Given this list of marker genes GNAS, UBTF, POLD4, VEZF1, HOXB6, FOXA2, FOXA3, KLHL5, SHQ1, ST7L, SRSF2, DNAJB5, PPOX, HS6ST3, ANGPT1, AMOT, TFAP2D, GRIK2, LHX6, TUBA1B, REPS2, KRIT1, ACTN1, NEURL1, MCTS1, DPYSL2, PLXNC1, PPP2R2A, GREM1, PHOX2B, LMO3, ABHD8, RAB34, SPEG, CDC27, ATXN7L2, NPNT, PDGFRA, ZNF335, FBXW7, GPBP1, OAZ2, TRA2A, HOXA10, SYNCRIP, NELFB, RPL8, NXPH3, RAB3C, CNNM1, ZNRF2, KPNB1 (NCBI Gene Id 3837), MFF, NFIA, SLC8A3, FAM131A (family with sequence similarity 131 member A), MPV17, POU3F1, LRP1, CAPZA1, HDAC3, SALL1 (NCBI Gene Id 6299), FBXW11, SLF2, PRKD2, WNT5A, SYN1, UBE2H, HNRNPL, VASP, DPH5, DNAJC27, PTK7, SLC39A5, UBXN10, DPF3, TMEM196, CRMP1, RELL2, YWHAE, SRRM1 (serine and arginine repetitive matrix 1), PHF6, GRIN2A, CNOT3, PDLIM4, PCYT2, PAFAH1B1, SYMPK, SPOP, NCDN, GATA3 (NCBI Gene Id 84828), MAML3, FKBP2, SP7, SP3, RBMS3, TTBK2, GRID2, TCF7L1, BLCAP (BLCAP apoptosis inducing factor), RBMS2, KCNB2, EIF4G1, TRIOBP, ABCB6, here is a description of the gene set: Human Gene Set: GATA2_01 Genes having at least one occurrence of the motif NNNGATRNNN in the regions spanning 4 kb centered on their transcription starting sites. This matches the GATA2 transcription factor binding site V$GATA2_01 (v7.4 TRANSFAC). studied in species Homo sapiens